The following is a description of a gene set: species: Homo sapiens Human Gene Set: CERVERA_SDHB_TARGETS_1_UP Recently, enzymes of the tricarboxylic acid (TCA) cycle have emerged as novel tumor suppressors. In particular, mutations in the nuclear-encoded subunits of succinate dehydrogenase (SDHB, SDHC, and SDHD) cause paragangliomas and pheochromocytomas. Although the mechanism(s) by which disruption of mitochondrial metabolism leads to neoplasia is largely unknown, increasing evidence points to an activation of pseudohypoxia. In this study, we have shown that silencing of SDHB using DNA-based small interfering RNA resulted in major impairments in cellular proliferation, respiration, and a corresponding shift to glycolysis. The levels of reactive oxygen species, however, were unchanged. As expected, hypoxia-inducible factor-1 alpha (HIF-1 alpha) and HIF-2alpha were up-regulated in chronically silenced cells, suggesting that a pseudohypoxic state was attained. In addition, the c-Jun amino-terminal kinase and p38 kinase stress signaling proteins were hyperphosphorylated in SDHB-silenced cells. Microarray analysis showed that >genes were influenced (6-fold or more up-regulation or down-regulation) by silencing of SDHB, confirming the importance of the TCA cycle in cellular metabolism. Examples of dysregulated genes included those involved in proliferation, adhesion, and the hypoxia pathway. Of interest, SDHB-silenced cells had a greater capacity to adhere to extracellular matrix components, including fibronectin and laminin, than control cells, thus suggesting a possible mechanism of tumor initiation. Although transient silencing of the HIF-1 alpha transcription factor in SDHB-silenced cells had little effect on the expression of a subset of up-regulated genes, it partially reversed the adhesion phenotype to fibronectin, pointing to a potentially important role for HIF-1 in this process. from publication Cervera AM, Apostolova N, Crespo FL, Mata M, McCreath KJ (PMID 18519664) Genes turned on in Hep3B cells (hepatocellular carcinoma, HCC) upon knockdown of SDHB by RNAi., and this is the list of marker genes: PLBD1, TNNI2, EPS8L1, SHOX2, MGARP, NOD2, ARHGAP23, FSTL1, CLIC6, GPX8, ACKR3, MAGEA3, LONRF2 (NCBI Gene Id 164832), PLEKHG4, PCDH9, TNFRSF19, PLXDC2, BAAT, PLEKHG4B, EDN1, SH3BGRL, UGT2B15, PCSK5, ITIH5, HPSE, PGM2L1, MFAP4, LYPD1, FHL2, SPOCK3, HTRA1, ANXA13, NBDY, COL1A1, SUSD5, SGCB, FAM149A, RIMKLA, APLP1, LYPD6B, TMEM54, AQP1, MAP1B, PTHLH, TMEM156, GALNT16, PIK3CD, VDR, WLS, BMERB1, LEFTY2, SLC1A1, RBP7, SLCO5A1, INHBA, DUSP4, PACSIN1, DNAAF3, ASCL1, ST6GALNAC2, SCD5, SLCO5A1-AS1, SUSD4, CAND2, ATP6V1C2, KRT80, GPR68, KIF3C, TMEM40, FAM81B, DYRK4, MCUB, CER1, ABLIM2, EMP2, FEZ1, RFTN1, GOLM1, HRG, PMAIP1, KRT17, MINDY4, CCDC74A, KBTBD11, LIPH, SCTR, NEURL1B, SCN4B, LMLN (leishmanolysin like peptidase), SUCNR1, UBASH3B, IGFBP2, CDC20B, SMPDL3B, JAM2, REEP1, NEURL3, TANC2, C2CD4A, MYOF, RIPOR3, S100A6, TUBA1A, RAB20, PTGER3, LOXL2, TNNT1, LHX2, SOCS2, ITGB6, WNT2B, SLC25A24, IL18, GALR2, IFIT2, PRSS23, CACNB3, OLFML2A (olfactomedin like 2A), MEGF6 (NCBI Gene Id 1953), LAMC2